Given this list of marker genes Abhd6, Dagla, Abhd12, Daglb, Mgll, here is a description of the gene set: species: Mus musculus Arachidonate production from DAG Mouse Gene Set: REACTOME_ARACHIDONATE_PRODUCTION_FROM_DAG